Given this list of marker genes MECP2, CKB, RPL10, NF2, NTRK2, BMP2, CHRNA1, THOP1, PFDN4, LYN (NCBI Gene Id 4067), HOXC4, IL1R1, DBNDD1, CHORDC1, IFT88, FKBP1B, KLHDC10, PIF1, LEAP2, SARM1, GPER1, NNT, ADA, KLK6, CBY1, MYLK2, ACTA1 (actin alpha 1, skeletal muscle), GATAD2A, CD40, TNFRSF14, CRNKL1, TBC1D2B, TRAM1, VASH2, EFTUD2, PCGF3, EXOSC4, ROPN1, RXRB, TRAF6, DLK1, NINJ1, DHODH, ELL, RPLP2, SSR3 (NCBI Gene Id 6747), PPP4R1 (NCBI Gene Id 9989), MARCKS, TXNDC16, ITGA8, RNF4, TECPR2, ME2, WWP1, TGFB1, SLC20A1, ZNF667, MGAT3, MAPT, LAMTOR1, PPP2R5D, PSMD2, SLC9A1, CTNNAL1, TRIM4, PTBP1, SETDB1, LIMS3, NUP54, CDC42SE2, PTMA, R3HDM1, EID1, SLC25A37, CD14, OXR1, LSM14A, TAGLN3 (NCBI Gene Id 29114), GABRA2, MYO1C, FADS1, MTMR2, RNF11, PNLIP, NPRL3, AUP1, SMYD5, ALG12, CC2D2A, PPP2R5C, THY1, H3-3B, LIMCH1, CLIC4, CCN3, PLAUR, PLPBP, RHAG, ZNF217, PRDM1, PRSS3, NCK1, NXN, TMEM97, ACACB, GATM, SLC25A16, here is a description of the gene set: species: Homo sapiens Human Gene Set: MODULE_147 GPCR.